Given this list of marker genes Fbn1, Mfap2, Efemp1, Bak1, Mir23a, Bhlhe23, Flt1, Hmgn1, Kdr, Bax, here is a description of the gene set: Mouse Gene Set: GOBP_POST_EMBRYONIC_EYE_MORPHOGENESIS species: Mus musculus The process, occurring after embryonic development, by which the anatomical structures of the eye are generated and organized. The eye is the organ of sight.